The following is a description of a gene set: species: Homo sapiens Human Gene Set: HP_ABNORMAL_DERMATOGLYPHICS An abnormality of dermatoglyphs (fingerprints), which are present on fingers, palms, toes, and soles. Abnormal dermatoglyphics, and this is the list of marker genes: EXT1, MED25, RERE, ZFX, COL17A1, KCNN3, CTBP1, SMC3, RIN2, BHLHA9, PEX10, TGDS, SMC5, SMS, ATP6V1B2, RPS23, NSDHL, KDM4B, FOXP1, DHCR7, KATNB1, STX1A, KRAS, ANKRD11, METTL27, TRIM37, PEX1, RTL1, NIPBL, ZMYM2, ATP6V1A, FGFRL1, TBL1XR1, NECTIN1, TMEM270, SLC39A13, PLOD3, LETM1, FBXO11, KCNK9, TSEN2, PEX11B, CLCN7, GJA5, SPRED2, STAG1, POLR1A, GJA8, TNNI2, BUD23, COL25A1, MAP1B, JARID2, NRAS, FIG4, RRAS2, PPP2R3C, NAA10, PTPRF, RIPK4, PIGL, CEP57, B3GLCT, TOE1, SET, EXTL3, MYOD1, VPS13B, FGD1, RASA2, TBL2, SETBP1, TBX5, PEX2, SOS1, SMAD2, UBR1, PEX13, CLIP2, TRIM8, GPR101, SPTBN1, PEPD, FKBP6, VPS37D (NCBI Gene Id 171020), DLX4, MCTP2, SMOC1, DOCK6 (NCBI Gene Id 57572), SHOC2, COX7B, UBE3B, CHD7, IFT122, RAPSN, TPM2, BRD4, SLC25A12, RPS6KA3, PEX12, MAP2K2, CILK1, POLRMT, ALDH6A1 (aldehyde dehydrogenase 6 family member A1), VPS51, RNU4ATAC, TSEN15, DDX11, B4GALT7, IGF1, MEF2C, LZTR1, HNRNPK, RBM10, PPP2CA, NALCN, COX14, NSD2, U2AF2, PEX3, LIFR, WDR37, AUTS2, ROR2, DLK1, FBXO28, IFT57, KMT2D, TAF4, PTPN11, HOXA13, ESCO2, RIT1, SLC25A24, TWIST1, CCBE1, SMARCA2, TYMS, RB1, TBX4, EZH2, DPH2, DNAJC30, TMEM147, DPH1, SALL4, SMARCAD1, TUBA1A, CKAP2L, DOK7, G6PC3, NOG, PGM2L1, CD96, PORCN, RAB11B (RAB11B, member RAS oncogene family, NCBI Gene Id 9230), CDC42BPB, TP63, ASXL3, OTUD5, ADAMTSL1, EP300, TFAP2A, ELN, LIMK1, SLC18A3, BAZ1B, CDK10, PEX14, NUP107, PEX6, KRT14, PAX1 (NCBI Gene Id 5075), NCF1, EBF3, HDAC8, DPYD, LTBP1, NDUFB11, RFC2, WAC, EIF4H, BCOR, SPECC1L, GTF2IRD2, HCCS, PRR12, SMC1A, HRAS, LMX1B, PEX16, XYLT1, CBL, MUSK, RAF1, TAF6, KDM6A, NXN, BMP4, TSEN54, PACS1, GLE1, YY1, FGF9, PIGS, PLAA, H3-3A, KAT6B, TSEN34, SEPSECS, LONP1, UFC1, COG1, NUP88, BRF1, IFT43, AFF3, NAA20, PPP3CA, DHODH, CSNK2A1, RAB3GAP1, UBR7, HDAC4, TRPS1, FGFR2, MTX2, DIS3L2, RAD21, RPL10, CPLX1, MTFMT, DEPDC5, CTCF, GTF2I, GPKOW, CCDC32, ARL3, BICD2, RAB3GAP2, MSL3, CHST3, TCF4, VPS33A, EHMT1, NEXMIF, MEGF8, TELO2, NGLY1, ATR, MYH3, PIGA, MAGEL2, ITCH, TBCK, GLYCTK, PEX26, GNB2, BRAF, MRAS, CEP55, PNPLA6, BMPR1B, TCF12, GDF5, NUP188, PDHA1, ASXL1, TNNT3, EYA1, SMPD4, ARID1B, STXBP1, FLNA, NBAS, FILIP1, MAP3K7, MEG3, AIP, LRP4, SCYL2, MTOR, KCNH1, CSGALNACT1, CREBBP, RRAS, GTF2IRD1, PEX19, ZNF292, DSE, PKDCC, ADNP, AHDC1, TRIO, PEX5, ATP6V0A2, PUF60, VAC14 (NCBI Gene Id 55697), H4C9, THOC2, KIF21A (kinesin family member 21A), RNU4-2, PIEZO2, CCNQ, MAP2K1, APC, DHX30, FGFR3, CDK19, CHST14, ASXL2, LTBP4, DPAGT1, ERGIC1, GRIN1, SPRTN, TASP1, ZNF462, SOS2, MED12